Given this list of marker genes Ptp4a2, Orc4, Myo5a, Iqcg, Gne, Syne1, Vdac2, Tapt1, Fbn1, Ark2c (arkadia (RNF111) C-terminal like ring finger ubiquitin ligase 2C), Atp8b4, Ano5, Ankrd49, Kcnma1, Scn3a, Ccna2, Pex3, H2az1, Crocc2, Wdr35, Ubr1, Lrrn3, Pax9, Ms4a4d, Bhmt, Asb8, Tspan18, Cd59a, Rad23b, Wnk4, Mcf2, Ntsr2, Tcf4, Slc26a10, C3ar1, Rcor1, Prkar2b, Apob, Chchd4, Dcp1a, Nop10, Ephx2, Tsr1, Spry2, Rabgap1l, Wnk1, Dmc1, Fgf10, Gpt2, Aff4, Pde3b, G3bp2, Rab7, Prkca, Nova1, 3830403N18Rik, Ly6g, Hmox2, Fmn1, Adss2, Entpd7, Stk3, Tmem243, Kctd6, here is a description of the gene set: from publication Chen Y, Wang X (PMID 31504780) studied in species Mus musculus Genes predicted to be targets of miRBase v22 microRNA mmu_miR_3066_5p in miRDB v6.0 with MirTarget v4 prediction scores > 80 (high confidence targets). Mouse Gene Set: MIR_3066_5P